Given this list of marker genes MT3, NOS3, PRM2, NOS1, SLC11A2, here is a description of the gene set: Human Gene Set: GOMF_CADMIUM_ION_BINDING species: Homo sapiens Binding to a cadmium ion (Cd).